The following is a description of a gene set: Any process in which a microtubule is maintained in a specific location in a cell. Human Gene Set: GOBP_MICROTUBULE_ANCHORING studied in species Homo sapiens, and this is the list of marker genes: NINL, BCCIP, PCM1, GCC2, CCDC187, DCTN1, CLASP2, GSK3B, CEP350, BICD1, CCDC120, DAG1, CCDC68, CEP20, CAMSAP3, CLASP1, MAP1S, CEP19, PEX14, NIN, HOOK3, BBS4, BICD2, CEP43, KIF3A